Given this list of marker genes RFC4, ARID1B, ING3, FAF1, EYA4, MCRS1, CCT8, PIAS4, SMARCD2, TFRC, ATR, TCP1, CCT2, VEGFA, UBE2N (ubiquitin conjugating enzyme E2 N), KAT7, TNKS2, SHLD2, CDC7, SMARCA5, BCL7A, CDC25A, KMT5C, ACTR8, RNF126, PDGFB, WAS, CDK2, RFC2, ACTB, CCT4, BRD8, KCTD13, FUS, RUVBL2, BRCA1, HNRNPD, RNF8, CTC1, SPIRE2 (NCBI Gene Id 84501), FOXM1, UIMC1, OOEP, IL4, AKT1 (NCBI Gene Id 207), DMAP1, TGFB1, PTGES3, POT1, PMS2 (NCBI Gene Id 91271), FANCB, EPC1, CHTF8, PHF10, WEE1, SMARCE1, CYREN, PDGFRB, CCT5, BRD7, DBF4B, TNF, HTR2A, FGF2, VPS72, MSH2, HDGFL2, HELQ, CEBPG, HSF1, TIMELESS, MORF4L2, SMARCC1, ACTL6B, POLG2 (DNA polymerase gamma 2, accessory subunit), CACYBP, NEK2, INO80C, FGF10, E2F7, DDX11, MAPK3, STK19, SLX1B, MARCHF6-DT, HNRNPA1, MAD2L2, TERF2IP, GLI1, MGMT, PRKCG, PRKCD, MORF4L1, DKC1, TMEM161A, CHTF18, BAX, NPM2, UBE2B, RFC3, CCNA2, PRKD2, DPF1 (double PHD fingers 1), CTNNB1, DBF4, ABRAXAS1, FGFR4, NVL, MAP2K7, BCL7B, GATA5, SMARCB1, EYA2, INO80B, SETMAR, KDM4D, KHDC3L, PTPRC, ERCC2, BCL7C, ACD, YY1, HNRNPA2B1, HGF, CCT7, DHX9, MAPK1, PKIB, RAD50, PRMT1, EXOSC3, WRN, CLCF1, CCT3, ZCWPW1, PRKCQ, SMCHD1, EYA3, GLI2, BRPF3, EGFR, FMN2, NFRKB, BRCC3, MRNIP, PARP3, SIRT1, DHX36, FBXO4, SKP2, RNF168, SSBP1, CIZ1, ERCC8, NEK7, AURKB, STAT6, PAXIP1, H2AX, BABAM2, SMARCC2, TBX21, TP53BP1, ATF1, RFC5, YEATS4, CD40, EREG, CCT6A, TNKS, RTEL1, SMARCD3, E2F8, DSCC1, EXOSC6, HMCES (NCBI Gene Id 56941), TIGAR, STN1, ATAD5, EYA1, TNFSF4, ARID1A, IL6, TINF2, HMGB1, MAPKAPK5, PRDM9, NAF1, NOX4, RAD51AP1, IL2, HSP90AA1, PBRM1, MAPK15, CDKN1B (NCBI Gene Id 1027), PPP1R10, CREBBP, CDT1, TNFAIP1 (TNF alpha induced protein 1), MEAF6, MBTD1, SLX1A, ERCC1, SMOC2, USP1 (ubiquitin specific peptidase 1), FAM168A, DPF3, RIF1 (NCBI Gene Id 55183), NSD2, SMARCA4, CBX8, RUVBL1, SHLD3, CDKN1A, ACTL6A, KAT5, ANKRD31, DPF2, NABP2, TNFSF13, DNA2 (DNA replication helicase/nuclease 2), MLH1, TRIM28, PRKDC, INO80, SMARCA2, CD28, BAZ1A, ACTR5, PARP1, UBE2V2, NPAS2, SPIRE1, KMT5B, MRE11, UCHL5, AGER, SLF2, INO80D (INO80 complex subunit D), MYC, EPC2, TFPT, HDAC10 (NCBI Gene Id 83933), WRAP53, EP400, SLF1, SHLD1, ENDOG (NCBI Gene Id 2021), GNL3, FGFR1, ERCC6, PARN, BABAM1 (NCBI Gene Id 29086), SMARCD1, KLF4, PCNA, PML, TOP2B, WDR48, PELI1, TERF2, ATRX, NBN, UCN, ACTR2, WIZ, RPS3, PNKP, SPIDR, ARID2, MAP3K4, TERF1, MRGBP, ATM, INO80E, SLX4, CDK1, FH (fumarate hydratase), PTK6, TRRAP, CCDC117, RGCC, SIRT6, here is a description of the gene set: Human Gene Set: GOBP_POSITIVE_REGULATION_OF_DNA_METABOLIC_PROCESS species: Homo sapiens Any process that activates or increases the frequency, rate or extent of the chemical reactions and pathways involving DNA.